Given this list of marker genes Brk1, Vil1 (villin 1), Clrn1, Plce1, Dnm2, Rreb1, Enpp2, Carmil2, Nckap1, Actr3, Aqp1, Actr2, Wnt1, Coro1b, Src, Cyfip1, Auts2, Avil, Cfl1, Rac2, Cdc42, Atp7a, Coro1c, Hdac4, Twf2, Wasf2, Akirin1, Mtor, Hsp90aa1, Abi2, Pik3r1 (phosphoinositide-3-kinase regulatory subunit 1), Fscn1, Mstn, Arpc2, Rac1, Frmd7, Carmil1, here is a description of the gene set: Mouse Gene Set: GOBP_POSITIVE_REGULATION_OF_LAMELLIPODIUM_ORGANIZATION studied in species Mus musculus Any process that activates or increases the frequency, rate or extent of lamellipodium organization.